The following is a description of a gene set: Mouse Gene Set: GOBP_POTASSIUM_ION_EXPORT_ACROSS_PLASMA_MEMBRANE The directed movement of potassium ions from inside of a cell, across the plasma membrane and into the extracellular region. studied in species Mus musculus, and this is the list of marker genes: Kcna2, Kcnt2, Wnk4, Kcne5, Kcnip1, Kcnb1, Kcnd3, Kcne4, Kcna5, Kcnn4, Kcnk18, Kcne3, Dlg1, Ano6 (anoctamin 6), Nppa, Kcnh2 (potassium voltage-gated channel, subfamily H (eag-related), member 2), Kcne1, Kcne2, Kcnq1, Kcnip2